Given this list of marker genes Minpp1, Inpp1, Bpnt1, Inpp4a, Mtmr7, Inpp4b, Inpp5d (NCBI Gene Id 98312), Inpp5k, here is a description of the gene set: Catalysis of the reaction: myo-inositol bisphosphate + H2O = myo-inositol phosphate + phosphate. studied in species Mus musculus Mouse Gene Set: GOMF_INOSITOL_BISPHOSPHATE_PHOSPHATASE_ACTIVITY